The following is a description of a gene set: Human Gene Set: GOBP_NEGATIVE_REGULATION_OF_CELL_DIFFERENTIATION Any process that stops, prevents, or reduces the frequency, rate or extent of cell differentiation. studied in species Homo sapiens, and this is the list of marker genes: G6PD, TRIM46, YBX1, DSG2 (NCBI Gene Id 1829), MIR21, NKX2-1, IL2, FOXA2 (forkhead box A2, NCBI Gene Id 3170), SIRT1, MIR19A, RANBP3L, CD74, MYB, CXCL10, MIR221, NF1, SPSB3, CCN4, WNT4, ZBTB7B, MIR486-1, NMRK2, TOB2, IL4R (NCBI Gene Id 3566), HDAC3, YY1, SPRY1, ITGB3, BCL6, JDP2, MAP2, BDNF, MIR137, H4C8, FOXG1, KLF13, BHLHA15, TREM2, PHOX2B, HSPA9, CDK5RAP2, ARHGAP4, TGFB1 (transforming growth factor beta 1), ZC3H8, PGLYRP1, NPHP3, ZEB1, IFNA2, REST, INSIG1, EIF4E, PRAMEF18, WWTR1, SMARCD1, FERMT2, PLPP7, MIR372, MAD2L2, HDAC5, NKX6-3, RAPGEF2, HPN, RCAN1, HDAC7, GSK3B, SORT1, LIMD1, USF3, ID2, EGFR, HNRNPU, ZBTB46, ADAMTS12, H4C6, PRAMEF22, RUNX1T1, ASCL1, NOTCH1, LBX1, GATA3, INHA, FOXE3, BICRA (NCBI Gene Id 29998), SEMA4D, TBX1, MAFB, DLX2, ASCL2, TWIST2, EPHB1, AXIN2, GPR68, NOCT, MIR10A, LIN28A, MIR30B, CHRD (NCBI Gene Id 96177), TP63, CTR9, NFATC1, MAG, HOPX, TSKU, CITED1, EPHA4, RBM15, H4C14, IL18, MIR199B, SOCS5, SOX3, TMEM119, TWIST1 (twist family bHLH transcription factor 1), BCL7A, IFNL1, PTK2B, LRP4, MIR302B, FOXP1, NOTCH4, DDX6, LGALS1, HEY2, PCM1, RYK, PGLYRP3, MIR27B, MIR27A, NKX3-2, TSC22D1, DLL3, NOTCH3, DAB1, RGS2, OVOL2, TCF15, RUFY3, ZBTB16, PDCD4, ZFPM1, YTHDF2, USH2A, CCND1 (NCBI Gene Id 893), HES1, SKIL, MIR214, PRMT1, VSX2, SORL1, MIR302A, IHH, COL5A1, MYOCD, BMP2, NTN1, IQCB1, NFATC2, FGF23, MIR19B1, H4C5, SMAD4, RARA, RIOX1, PRAMEF13, ULK1, IFNG, CDK13, ID1, TAOK3, PTHLH, SOD2, IRX3 (NCBI Gene Id 79191), SPRED3, TRPM4, WNT7A, RARG, MIR204, GDI1, MIR573 (NCBI Gene Id 693158), PRAMEF8, CFL1, NR5A2, SEMA3G, DICER1, ZNF750, SOCS1, DIP2B, HES5, ABCG1, HMGA2, LMX1A, SOX8, PRDX2, FLCN, IL17RD, CLEC12A, DDIT3, MIR15B, ULK2, COL5A2, RBPJ (NCBI Gene Id 51580), MIR100, KIFAP3, PAX6, TRIB2, TCTA (NCBI Gene Id 6988), FOXA1, VEGFA, ID4, KRAS, GPR55, SOX10, SMAD6, CDK6, TMEM176A, TRIB1, SMAD7, SPART, MAPK1 (NCBI Gene Id 5594), PRAMEF25, AREG, NTRK3, CD69, DTX1, ACVR1B, NELFB, EREG (NCBI Gene Id 2069), GORASP1, SPRED1, CNTN2, KCTD11, MIR9-1, JAG1, SMARCA4, SUFU, CRP, GABPA, MDK, DUSP10, LRP3, WNT5A, BHLHE41, OSR1, NODAL, SLIT1, MIR142, ANKRD26, PTCH1, HOXA7, PSEN1, GLI3, CAV3, GSK3A, PF4, H4C1, BMPR2, CTNNA1, CETP, FGF10, MIB1, MIR379, SEMA5A, CR1, FRS2, IL17D, MYC, PAK1, H4C15, PRAMEF19, MIR205, TMEM98, PRAMEF2, PITX3, MIR103A1, RBPMS2, PTH, DAB2IP, MIR1-1 (microRNA 1-1), MIR24-1, TOB1, CIB1, CNTN4, MIR98 (NCBI Gene Id 407054), ZFP36L2, ESRRB, CTDP1, INPP5D, LEO1, MIR548D1, FZD7, IPO7, SMAD1, BICRAL (BICRA like chromatin remodeling complex associated protein), IL1B, PRAME (PRAME nuclear receptor transcriptional regulator), UBASH3B, EZH2, DKK1, CCDC85B, MMP9, DACT3, FOXJ1, ZFP36L1, PRAMEF17, H4C4, MIR200B, TGFB1I1, MIR18A, SPP1, ZNF536, HMGB3, ATOH1, ID3, SDHAF2, H4C13, FOXO1, TGFB2, FSTL4, S1PR3, NEPRO, MIR483, STAT5B, AKIRIN1, FOXO3 (NCBI Gene Id 2309), MIR149, HDAC4, SMAD3, HOXA2, ZFHX3, CEACAM5, MIR125B1, H4C12, BCL7C (BAF chromatin remodeling complex subunit BCL7C), MED1, SS18, GPR137, ACTL6B, PGLYRP2, CUL4A, SMO, SOX4, NOG, APCS, ENPP1, MEN1, LILRB1, TNFAIP6, ADIPOR1 (NCBI Gene Id 95409), LILRB4, PPARA, IFRD1, YPEL4, SIX2, CCL3, RAP1GAP, TRIM62, CLDN18, MIR181C, MIR140, BRD9, REG3A (regenerating family member 3 alpha), PTEN, GDF3, NKX6-2, TENT5C, HOXB8, SINHCAF, TWSG1, PTPRS, REG3G, FBXO11, PRAMEF33, MIR144, PPARD, RPL3L, FUOM, FST, MIR222, ISL1, SOX6, BTG2, OLIG2, TLX2, FUZ, TRIM72, LDLRAD4, CDK12, BMP4, LRRC17, TTPA, RGS4, WNT3A (Wnt family member 3A), FRZB, ZNF675 (NCBI Gene Id 171392), RTN4, DLL1, LAG3, RFLNA, CDKN2A, CALR, FSTL3, LTBP3, CTNNB1, PRAMEF4, TNF, SLC7A10, PKP2, STAT1, PTN, RGMA, RAG2, ISL2, IDH2, TNR, SHOC2, TBX21 (NCBI Gene Id 30009), NKX6-1, TBX6, EID2B, TLX3, CNTF, FGF13, RORB, FGL2, WNT10B, MT3, SUZ12, LBH, GPS2, MIR107, TNFRSF11B, MIR181B1, TMEM64, PRAMEF12, CDKL3, PIK3R1, SYNGAP1, ITGB1, PTGR3, PRAMEF5, EPHB2, SPDEF, MIR93 (NCBI Gene Id 407050), ASPM, TRIO, PRAMEF26, PDGFB, WNT9A, TRPC5, MSX2, RUNX3, SEMA4F, BMAL1, GREM1, TMEM176B, CDH1, VAX1, IGFBP5, PROX1, ABCA1, NFATC3, BAMBI, PTPN2, SIX4, TRPV4, TLCD3B, CDK5, MIR29B1, TSPO (translocator protein), OSTN, FBXO7, MYCN, H4C3, RARB, MIR208A, TP53INP1, SLC6A4, NFKBIA, STAT3, RNF10, INHBA, CHADL, CERS2, H4C16, PRAMEF1, RFLNB, MSTN, TNFSF4, ITGAV, PRAMEF15, BCL11A, PBX1, HEY1 (NCBI Gene Id 23462), PLXNA3, RUNX1, GPR37L1, PRAMEF9, PPARG, MCF2, NKX2-2, SOX2, CLEC4G, IFNB1, SMARCA2, MSX1, LOXL3, IL13, AXIN1, S100B, CALCA, TRIM6, NR1H3 (nuclear receptor subfamily 1 group H member 3), DYNLT1, ZFPM2, TUNAR, CDC73, ACTB, LYN, TP53 (NCBI Gene Id 7157), CCL11, TNFSF18, IL4, SOX9, STAT5A (NCBI Gene Id 6776), CTLA4, NFATC4, QKI, HLX, CBFB, MIR675, RTN4R, MIR203A (NCBI Gene Id 406986), B2M, MEIS2, SEMA6C, PI16, MIR106A, LILRB3, EXTL3, SRSF6, DLX1 (distal-less homeobox 1), EIF4ENIF1, NKX2-5, MIR202, ANKRD2, MIR146A, RC3H1, ZFP36, LDLR, H4C2, PRDM16, MIR320A, TMEM131L, MIR590, ERFE, DNMT1, HDAC6, RNF6, ABCC8, FCGR2B, CRIM1, SMARCC1, PRAMEF10, WNT3, JAK3, PRAMEF27, MECP2, TLR3, PTBP1, MIR145, ADIPOQ, VASN, TMSB4X, THY1, CAV1, EFNB3, POU4F2, DISP3, EFNA1, NBR1, PIAS3, MIR130A, NR2E1, SNAI1, SOX11, NF2, LDB1, H4C9, PRTG, NPPC, BMPR1A, CTDSP1, ELF5, TCF23, PPP3CA, IRF1, ADGRV1, PRMT5, VEGFC, C1QL4, RC3H2, SHH, HMG20A (high mobility group 20A), WEE2, TOMM70, TRPC6, DAAM2, TGFBR1, BCL7B, IGF1, BMP5, MIR26A1, TMEM53, TRIB3, LHX2, MESP1, SFRP1, KAT8, TBX3 (T-box transcription factor 3), EDNRB, DNAJB11, ACTL6A, TMEM182, SPRED2, E2F1, ZBED6, MEIS1 (NCBI Gene Id 4211), NFE2L2, CEACAM1, MIR130B, C1QC, PCID2, HOXA5, SNAI2, CEBPA, PAEP, PRAMEF6, NR1H2, TRIM11, TBX5, PRAMEF14, UCMA, MIR518B, TNPO2, RORA, TRAK2, MED28, GPR137B, LRP5, ERBB2, YWHAH, MIR17, KIAA0319 (NCBI Gene Id 9856), GPR171 (G protein-coupled receptor 171), LSM1, N4BP2L2, CSRP3, PTPN11, PRAMEF20, FEZF2, SIRT2, GPER1, SYT4, PRAMEF7, MMP11, XBP1, EFEMP1, PRDM6, TLR4, FOXJ2, TMEM178A, PRAMEF11, GATA2, DRAXIN (dorsal inhibitory axon guidance protein), LTF, BRINP1, HLA-G, NRARP, GDF5, ZC3H12A, NR1D1, MIR495, PAF1, SMAD2, HOOK3, DPYSL5 (NCBI Gene Id 56896), SRA1, APPL2, SKIC8, HOXA9, EIF2AK4, FGF9, SFRP2, YAP1, WNT1, SLC4A2, IAPP, SEMA3F, FOXO4, FOXP3, TP73, CARTPT, PRICKLE1, ANXA1, CMTM5, H4C11, MIR199A1, SPAG9, ITPKB, MIR138-1, ACVRL1, BBS12, EPHA7, BMP8B, DIXDC1, SPRY2, SEMA6D, ZHX2, FBXW7, SOSTDC1, ABCA5, BMP7, RB1, HDAC1, METTL14, IL6, ASXL1, IGF2, ANP32B, MBNL3, SIX3, SKI, PPP2CA, GDF11, SHB, MIR128-1, HAND2, DPF2, F2, NPR2, NRP1, MIXL1, MIR448 (NCBI Gene Id 554212), HMGB1, DCC, DRD3, MIR18B, CCN3, MARK1, FBN1, ADAMTS7